Given this list of marker genes TGM2 (transglutaminase 2), ELL2, SNTB2, PPARG, PCK2, PALLD, LXN, RNF14 (ring finger protein 14), SASH1, SGTB, STK11IP, UACA, AP1AR, TMEM140, HIF1AN, SLC35A2, C11orf96, PLEC, NAGLU, MSTO1, LGALS3BP, CDCP1, CCND1, CALU, MMD, MGLL, NUPR1, SCN1B, SH3PXD2A, SLC46A1, MLLT1, CASP10, GIMAP6, DHODH, SCD, HS1BP3, MMP19, BCL2L1, GAS2L3, FPR3, CEP41 (NCBI Gene Id 95681), HSD3B7, SLC11A2, EPB41L2, UPP1, EDC3 (enhancer of mRNA decapping 3), RRAGD, IL18, RCAN1, PHACTR2, PRADC1, FNDC3B, AP5S1, CD82, ACOT2, CD58, DPH6, MFSD12, FAM120B, TNFSF12, PLA2G15, HK3, TWF1, OAS3, APPL2, CUL9, SIGLEC1, ZBTB24, CREB3, ALKBH4, SLC38A7, TIMD4, GAL3ST4, DDX60L, PLD1, ADORA3, EMP1, PCYT2, B3GALT4, EPAS1, TRIM14, GBP2, TMEM94, SDC2, ACOT13, SMUG1, CXCL12, PATL2, GNA12, MMP2-AS1, VEGFB, PIP5K1C, NR1H3 (nuclear receptor subfamily 1 group H member 3), SNX24, SACS, KCNJ5, SLC26A11, FEZ1, DENND4C, ABCC5, SENP5, DAPK1, TTLL4, HECTD3, FARP1, ITSN1, VAMP5, ME1, CLIC2, CEACAM21, DST, SGSH (N-sulfoglucosamine sulfohydrolase), ZFYVE21, RAB7B, NRP2, TOR4A, MYO7A, CMKLR1, ARHGAP10, RAB42, STARD8, IFIT2, NOL9, ZNF480, ARHGAP21, LYSET, GFER, IFI27, PDZD11, APOL1, TMEM138, CD151, LPCAT3, SLC37A2, C1orf122, BACE2, CPNE2, TPD52, UBA5, TMEM176A, CXCL3, ANKRD9, USP40, NTMT1, IKBKE, TGFBRAP1, SIL1, RARRES1, AP5B1, SULT1A2, TCN2, SPECC1L, SELENBP1, CD9, DPY19L3, PPFIBP2, PAPSS1, GFM2, SPP1, DUS4L (NCBI Gene Id 11062), SUCNR1, IFIT3, TMIGD3, RASGRP3, FAM20C, PDHX, CBFB, PLVAP, MORN2, GCN1, GFRA2, WDR55, RAB35, UBASH3B, IFIT1, TREM2, LMNA, UBA6-DT, VCAM1 (NCBI Gene Id 7412), ZNF654, TPCN2, HERC5, IFI6, KIAA1217, BSCL2, HLA-F, ICMT, PAPSS2, BCAR3, HPSE, NECTIN2, TMEM9, COPRS, SETBP1, SLC35A4, ZNF260, FBP1, CADM1, APOE, DERL1, MFAP1, ABCC3, S1PR1, OPTN, TOR1B, BRF2, APOL6, SIGLEC11, PGM2L1, ZNF76, NIBAN2, INTS5, PLA2G7, GPR137B, TNS1, CD276, CENATAC, TSPAN15, DCHS1, CD38, PANK3, NUAK1, ACBD5, VPS37C, IFI44L, SLC38A6, CD59, EPSTI1, ENPP2, CMPK2, PLEKHM2, TRIM47, BAP1, EEF2KMT, IFI44, EEPD1, KCMF1, FAM78A, FBXW2, SDC3, ADAM9, LACC1, ERRFI1, CHCHD6, BRD1, PWP2, C6orf120, PDLIM7, ZER1 (NCBI Gene Id 10444), TECPR2, MERTK, SIGLEC9, BCAP29, MX1, MAGEH1, OTOA, VMO1, TRMT61B, CD40, DHX35, INF2, SQOR, CYSTM1, CDK18, IER3IP1, C1orf54, SLC44A2, MRPL1, CERS4, ITGA9, RIGI, LONP1, SLC29A3 (solute carrier family 29 member 3), NCEH1, CENPB (NCBI Gene Id 92501), ABCG1 (NCBI Gene Id 9619), VAT1, NPDC1 (neural proliferation, differentiation and control 1), PHYH, LINC03070, PDGFC, PICK1, KCNMA1, RAB3GAP2, TP53I3, FLVCR2, MAIP1, JKAMP, TFPT, IFT74, ACVRL1, TCTN1, POLR3A, GPNMB, FECH, DNASE2, VPS54, IL10, SLC39A11, PRXL2A, GPR89A, CD209 (NCBI Gene Id 30835), C11orf98, SERPING1, SIKE1, AGAP3, WDR81, DEXI, ATP13A2, EBI3, ACP2, UCKL1, SLC7A8, FCGR3B, FXYD6, AMDHD2, RPP25, PDE6G, FAM114A1, PELATON, SLC1A3 (NCBI Gene Id 6507), IL4I1, LHFPL2, IGSF21, ETV5, OGFOD2, DHRS7B, TNS3, HAGHL, MITF, ZMAT5, ADCK2, MSR1, TCEAL3, SH3YL1, SMYD3, DNASE1L1, ZNF134, SMPD1, PNPO, RMND5B, C2, PLOD3, XAF1, FMNL2, CTSF, GSAP, ANPEP, ZNF585A, IQSEC2, PFKP, ABITRAM, SPIC, PGPEP1, ACP5, ANKH, SLC35F6, DNMT3A, TMEM176B, DHX58, HYAL2, FERRY3, APOC1 (apolipoprotein C1), CARM1, SLFN5, GRAMD4, TTC27 (NCBI Gene Id 55622), EIF2AK2, CCDC117, GRK3 (NCBI Gene Id 157), PPME1, STOM, EXT2, CD5L, SDSL, PPIC, RHOBTB1, TMEM203, CYP27A1, CD72, RALGDS, GALM, HSD17B14, NDST2, IGF2R, TSC1, LZTR1, TDP2, GBA1, EPHX1, SMPDL3A, RNF26, MED31, MTNAP1, CREB3L2, OAS2, FCGBP, ID1, DTX3L, FCGR3A, BCAM, H4C16, CETP, GPX3, NFAM1, PGM3, ACOX1 (acyl-CoA oxidase 1), HMGXB3, TTC38 (NCBI Gene Id 55020), DNAJC30, ZNF26, TMEM220, RIDA, GBP1, MFSD5, MCM4, CHST10, LDAH, MYO9A (NCBI Gene Id 80251), LZTFL1, SIGLEC7, DARS2, FABP3 (NCBI Gene Id 337956), TANC2, TNFRSF21, NFE2L3 (NCBI Gene Id 9603), LRRC28, SLC36A1, CCDC106, ZXDC, KIFC3, KCTD7, DENND11, CCZ1B, METTL13, PARP12, GAS2L1, C11orf54, NMRK1, PLBD2, MFHAS1, PLXNA1 (plexin A1), ACADS, LINC01645, COPS8, RNLS, SPRING1 (NCBI Gene Id 79794), DYSF, BOLA3, PCBD2, SOCS6, RMDN3, ZNF669, MYO1E, KLHDC8B, NAB2, LRRK1, DENND2D, SULT1A4, RCL1, EEIG2, GALK2, SGPL1, PYROXD1, A1BG, TMEM37, SAMD9L, HIVEP3, CUEDC1, SREBF1, RNF217, C15orf48, SLC22A18, SLC48A1, IFIH1, SERINC2, here is a description of the gene set: studied in species Homo sapiens Human Gene Set: HE_LIM_SUN_FETAL_LUNG_C2_APOE_POS_M2_MACROPHAGE_CELL APOE+ Mφ2 from publication He P, Lim K, Sun D, Pett JP, Jeng Q, Polanski K, Dong Z, Bolt L, Richardson L, Mamanova L, Dabrowska M, Wilbrey-Clark A, Madissoon E, Tuong ZK, Dann E, Suo C, Goh I, Yoshida M, Nikolić MZ, Janes SM, He X, Barker RA, Teichmann SA, Marioni JC, Meyer KB, Rawlins EL (PMID 36493756)